The following is a description of a gene set: Pulp calcification Pulp calcifications may appear as punctate calcifications, irregular, roughly spherical mineralized masses in any part of the pulp. It may occur isolated or associated to calcifications elsewhere such as the carotid arteries and kidneys. The diagnosis pulp calcifications can be established using radiological studies. studied in species Homo sapiens Human Gene Set: HP_PULP_CALCIFICATION, and this is the list of marker genes: COL5A1, DSPP, FGF3, COL1A1, COL5A2, GALNT3, FAM20A